Given this list of marker genes TUBB2A, TUBA1B, TUBB4A, HAUS6, TUBA3C, HAUS2, TUBB6, TUBGCP6, HAUS4, TUBB4B, TPX2, MZT2A, TUBB8, TUBB1, MZT2B, TUBGCP4, TUBA4A, TUBA8, NEDD1, HAUS3, TUBA3E, HAUS5 (HAUS augmin like complex subunit 5), HAUS8, TUBB3, TUBGCP5, TUBA1A, HAUS7, TUBB, TUBGCP2, TUBA3D, TUBA1C, TUBB2B, TUBGCP3, here is a description of the gene set: studied in species Homo sapiens Pathway Definition from KEGG: gamma-TuRC == Augumin == TPX2+microtubule Human Gene Set: KEGG_MEDICUS_REFERENCE_BRANCHING_MICROTUBULE_NUCLEATION Branching microtubule nucleation. Pathway ID: N01549. Pathway type: Reference. Pathway class: nt06515 Regulation of kinetochore-microtubule interactions.